Given this list of marker genes Nr2f6, Nr4a1, Esrrg, Rorc, Rxrg (retinoid X receptor gamma), Nr1i2, Pgr, Rorb, Rara, Nr3c2, Esr2, Nr0b1, Ppara, Nr0b2, Vdr, Esr1, Nr1i3, Esrrb, Nr5a1, Nr1h3 (nuclear receptor subfamily 1, group H, member 3), Nr3c1, Rxra, Nr2c2, Ar, Med1, Thra, Nr1d1, Nr1h2, Nr2e3, Nr2c1, Ncor2, Nr6a1, Rora, Rarb, Nr1d2, Rxrb, Hnf4a, Esrra, Nr4a3, Nr5a2, Ppard, Rarg, Nrbf2, Nr4a2, Nr2f1, Nr2e1 (NCBI Gene Id 21907), Nr1h4, Thrb, here is a description of the gene set: Mouse Gene Set: REACTOME_NUCLEAR_RECEPTOR_TRANSCRIPTION_PATHWAY studied in species Mus musculus Nuclear Receptor transcription pathway